Given this list of marker genes Nnat, Lhfpl4, Phlda1, Mfap4, Meox1, Junb, Grb14, Egr1, Zbtb12, Dnajc5g, Ddb1, Kctd15, Tbl2, Utp6, Grem2, Slc22a6 (solute carrier family 22 (organic anion transporter), member 6), Tuba4a, Dusp4, Tac1, Krt84, Rnd3, here is a description of the gene set: from publication Bilanges B, Argonza-Barrett R, Kolesnichenko M, Skinner C, Nair M, Chen M, Stokoe D (PMID 17562867) studied in species Mus musculus Mouse Gene Set: BILANGES_SERUM_SENSITIVE_VIA_TSC1 The tuberous sclerosis complex (TSC) proteins TSC1 and TSC2 regulate protein translation by inhibiting the serine/threonine kinase mTORC1 (for mammalian target of rapamycin complex 1). However, how TSC1 and TSC2 control overall protein synthesis and the translation of specific mRNAs in response to different mitogenic and nutritional stimuli is largely unknown. We show here that serum withdrawal inhibits mTORC1 signaling, causes disassembly of translation initiation complexes, and causes mRNA redistribution from polysomes to subpolysomes in wild-type mouse embryo fibroblasts (MEFs). In contrast, these responses are defective in Tsc1(-/-) or Tsc2(-/-) MEFs. Microarray analysis of polysome- and subpolysome-associated mRNAs uncovered specific mRNAs that are translationally regulated by serum, 90% of which are TSC1 and TSC2 dependent. Surprisingly, the mTORC1 inhibitor, rapamycin, abolished mTORC1 activity but only affected approximately 40% of the serum-regulated mRNAs. Serum-dependent signaling through mTORC1 and polysome redistribution of global and individual mRNAs were restored upon re-expression of TSC1 and TSC2. Serum-responsive mRNAs that are sensitive to inhibition by rapamycin are highly enriched for terminal oligopyrimidine and for very short 5' and 3' untranslated regions. These data demonstrate that the TSC1/TSC2 complex regulates protein translation through mainly mTORC1-dependent mechanisms and implicates a discrete profile of deregulated mRNA translation in tuberous sclerosis pathology. Genes translationally up-regulated by serum in MEF cells (embryonic fibroblast) lacking TSC1.